The following is a description of a gene set: Human Gene Set: GOBP_NEGATIVE_REGULATION_OF_THYMOCYTE_APOPTOTIC_PROCESS Any process that stops, prevents, or reduces the frequency, rate or extent of thymocyte death by apoptotic process. studied in species Homo sapiens, and this is the list of marker genes: PTCRA, HIF1A, BCL11B, BMP4, KIFAP3, ADA, RORC, JAK3, RAG1, EFNA1